The following is a description of a gene set: Human Gene Set: chr15q11 studied in species Homo sapiens, and this is the list of marker genes: IGHV4OR15-8, GOLGA6L2, SNORD115-5, SNORD115-27, SNORD116-7, MKRN3, OR4N3P (NCBI Gene Id 81106), SNORD116-1, NIPA1, SPATA31E2P, SNORD116-10, SNORD115-47, MIR3118-4, SNORD115-30, SNORD115-41, ZNF519P3, MIR3118-2, SNORD116-20, SNORD115-23, ENSG00000287888, IGHD5OR15-5A, RN7SL759P (RNA, 7SL, cytoplasmic 759, pseudogene), IGHD2OR15-2A, SNORD115-15, SNORD115-19 (small nucleolar RNA, C/D box 115-19), CYFIP1, ENSG00000310519, SNORD116-2, SNORD115-26, SNHG14, ENSG00000281087, SNORD115-28, NIPA2, GOLGA8IP, SNORD116-9, OR4Q1P, FAM30C, SNORD116-15 (small nucleolar RNA, C/D box 116-15), OR11J7P, SNORD116-6, SNORD116-24, SNORD116-14 (NCBI Gene Id 100033426), SNORD116-30, SNORD115-18, RN7SL536P (RNA, 7SL, cytoplasmic 536, pseudogene), SNORD115-37, SNORD115-17 (small nucleolar RNA, C/D box 115-17), SNORD116-17, MIR5701-1, SNORD116-11, MPHOSPH10P5, SNORD115-36, HERC2P3, SNORD116-16, SNORD116-29, BMS1P15, POTEB2, SNORD115-7, BMS1P16 (NCBI Gene Id 727914), GOLGA8S, RN7SL495P, POTEB3, HERC2P7, NBEAP1, SNORD115-43, OR1Q1BP, MPHOSPH10P4, GOLGA6L22, SNORD116-21, SNORD115-9, MIR3118-3, GOLGA6L6, RNU6-631P, SNORD115-48, SNORD115-35, RPS27P2, SNORD116-13, SNORD116-28, OR11J2P, OR11J6P, SNORD115-12, LONRF2P4, SNORD115-22, IGHD3OR15-3A, SNORD115-1, SNORD115-40, OR4N4C (olfactory receptor family 4 subfamily N member 4C), CHEK2P2, IGHD4OR15-4B, MPHOSPH10P6, IGHD2OR15-2B, SNORD115-16, NPAP1 (nuclear pore associated protein 1), PWAR1, RNU6-749P, SNORD115-44, IGHD3OR15-3B, LINC02203, SNORD116-12, SNORD107, GOLGA6L26, SLC20A1P3, SNORD108, SNORD115-38, IGHV3OR15-7, ZNF519P2, RPS8P10, SNORD115-4, IGHD5OR15-5B, PWAR5, RNU6-498P, SNORD109B, PWRN4, SNORD115-14, RNU6-741P, GOLGA8EP, GRAMD4P5, SNORD115-11, HERC2P6, OR4M2-OT1, RN7SL584P, FAM30B, MIR5701-3, IGHD4OR15-4A, IGHV1OR15-4, SNORD115-46, OR11H3P, ENSG00000286598 (NCBI Gene Id 105370728), SNORD116-27, SNORD115-33, OR4H6BP, ENSG00000290912, ELMO2P1, MIR1268A, PWRN1, SNORD115-34, SNORD116-23, SNORD116-4, RNU6-1235P, SNORD116-3, BCAR1P1, OR4H6P, DMAC1P1, SNRPN, OR11K1BP, SNORD109A, IGHV1OR15-9, NDN, SNORD115-20, SNORD115-6, RN7SL400P, SNORD115-24, OR4N4, NF1P9, SNORD116-8, GOLGA8CP, MIR4509-1, BCAR1P2, RHPN2P1, SNORD115-42, GOLGA8DP, SNORD115-13 (small nucleolar RNA, C/D box 115-13), IGHV1OR15-6, SNORD116-5, IGHV1OR15-1 (NCBI Gene Id 388077), LONRF2P3, SNORD115-2, TUBGCP5, RN7SL106P, OR11K1P, SNORD115-29, SNORD64, MIR5701-2, MPHOSPH10P9, SNORD115-25, HERC2P2, SNORD116-22, ENSG00000275174, IGHV1OR15-2, NBEAP4 (NCBI Gene Id 100418897), SNURF, SNORD115-21, SNORD115-10 (NCBI Gene Id 100033447), OR4M2, POTEB, RNU6-978P, SNORD116-26, CXADRP2, RPL5P1, WHAMMP3, SNORD116-18, PDCD6IPP1, LINC01193, MIR4508, SNORD116-19, SNORD116-25 (small nucleolar RNA, C/D box 116-25), OR4M2B (olfactory receptor family 4 subfamily M member 2B), SPATA31E3P, ABCB10P1, SNORD115-31, GOLGA6L1, IGHD1OR15-1A, SNORD115-39, ENSG00000274253, GRAMD4P6, OR11J5P, OR4N3BP, SNORD115-8, SNORD115-45, UBE3A, SNORD115-32, IGHV1OR15-3, MAGEL2, NF1P2, IGHD1OR15-1B, RN7SL545P, PWRN2, SNORD115-3, NF1P1